Given this list of marker genes Slc17a6 (solute carrier family 17 (sodium-dependent inorganic phosphate cotransporter), member 6), Tmco3, Slc35d1, Slc30a4, Slc30a3, Slc26a3, Slc18a3, Slc9a3, Slc1a5, Slc9b1 (NCBI Gene Id 99862), Slc30a9, Slc25a13, Slc38a3, Slc24a2 (solute carrier family 24 (sodium/potassium/calcium exchanger), member 2), Clcn5, Tmem165, Clcn7, Slc25a19, Chp1, Slc26a9, Slc9c1, Slc35b3, Slc25a17, Slc35e1, Slc24a4, Slc9a7 (NCBI Gene Id 278183), Slc38a5, Slc26a6, Slc9a4, Slc26a10, Slc18a1, Tmem241, Slc47a2, Slc35a1, Slc8a2, Slc44a4, Slc25a10, Slc30a5, Slc35c1, Slc26a5, Slc4a2, Slc25a12, Clcn3, Slc35e3, Slc41a1, Slc9a6, Slc26a1, Slc7a8, Slc24a1, Slc32a1, Slc24a5, Slc17a7, Slc35e4, Slc37a2, Slc8a1, Slc9a9, Slc22a6, Slc25a4, Slc9a5, Slc18a2, Slc25a23, Slc4a9, Slc25a21 (solute carrier family 25 (mitochondrial oxodicarboxylate carrier), member 21), Slc44a1, Slc44a2, Letm1, Slc9a1, Slc9b2, Ucp2, Slc4a1, Slc30a2, Slc26a2, Slc4a10, Slc7a5, Slc7a11, Slc25a1, Slc25a5, Slc25a11, Slc22a8, Slc24a3, Slc4a11, Slc7a6, Slc7a9, Slc26a4, Slc30a10, Slc44a5, Slc6a4 (NCBI Gene Id 216958), Slc9a8, Slc7a13, Slc25a30, Slc35b2, Slc25a15, Slc19a1, Slc26a7, Slc9a2, Slc8b1, Slc25a26, Slc30a8, Slc4a7, Slc35d3, Ghitm, Slc4a4, Slc35b1, Slc25a31, Clcn6, Slc35a2, Slc4a5, Slc41a3, Clcn4, Slc25a25 (solute carrier family 25 (mitochondrial carrier, phosphate carrier), member 25), Slc25a14, Slc35a5, Slc35e2, Slc35c2, Slc47a1, Slc4a3, Slc8a3, Slc37a4, Slc30a1, Slc11a1, Slc37a1, Slc35a3, Slc35d2, Slc26a8, Slc4a8, Slc25a24, Slc18b1, Slc26a11, here is a description of the gene set: species: Mus musculus Enables the active transport of a solute across a membrane by a mechanism whereby two or more species are transported in opposite directions in a tightly coupled process not directly linked to a form of energy other than chemiosmotic energy. The reaction is: solute A(out) + solute B(in) = solute A(in) + solute B(out). Mouse Gene Set: GOMF_ANTIPORTER_ACTIVITY